Given this list of marker genes BBS4, RHPN2P1, ANKRD23, ARHGAP6, TACR1, TGFBR1, SDC4, MIR1-1, TJP1, SLC9A1, ROCK2, MIR138-1 (NCBI Gene Id 406929), WNT4, STMN1, RGCC, PPM1F, ARAP1, WASF2, CD47, CARMIL1, LPAR1, DLC1, MYLK3, ARHGEF15, CCDC88A, RAC1, RHPN2, RHPN1, GPR65, RHOA, ARHGEF5, FHOD1, ARHGEF18, PAK1, SMAD3, OAZ3, AKAP13, CLASP2, FRMD7, TESK1, PFN1, CORO2B, LIMK1, ALMS1, INPP5K, S100A10, NRP1, CCN2, PPFIA1, CAV3, SYNPO, NF2, APOA1, MIR149, PAK2, TTC8, PTGER4, MTOR, MET, SORBS3, BAG4, TSC1, LIMCH1, TGFB3, ARHGEF10, BRAF, PIK3R2, FERMT2, TPM1, PHLDB2, CGNL1, SERPINF2, ECT2, ITGB1BP1, MKKS, SFRP1, SMAD4 (SMAD family member 4), PXN, F11R, RHOC, AMOT, TACSTD2, CDC42, PIK3R1, PFN2, BMP10, WAS, ARHGEF10L, MIR21, ROCK1, ARHGAP28, ACTG1, ASAP3, PPM1E, EDN1, PRKD1, EVL, TAC1, ABL1, SYNPO2L, RAPGEF3, S1PR1, PROX1, EPHA1, TMEFF2, CLASP1, MIR20A, MYOC, here is a description of the gene set: Human Gene Set: GOBP_REGULATION_OF_ACTOMYOSIN_STRUCTURE_ORGANIZATION Any process that modulates the frequency, rate or extent of the assembly, arrangement of constituent parts, or disassembly of cytoskeletal structures containing both actin and myosin or paramyosin. studied in species Homo sapiens